Given this list of marker genes Apoe, Htt, Pld1, Ctss, Egfr, Mtm1, H2-Oa, Lamp3, H2-Aa, Ap5b1, Lamp1, Tspan15, Snf8, Rapgef2, Rab9, Mmd, Stard3, Nmnat2, Mcoln3, Slc9a6, Mapkap1, Rnf133, Lamtor1, Ankrd13d, Ifnar1, Pikfyve, Ankrd27, Yipf2, H2-Eb1, Chid1, Kcmf1, Chmp1b2, Ifitm3, Ifitm2, Cd2ap, Ubxn6, Dync1li1, Mtmr4, Atg9a, Abcb6, Sorl1, Osbpl11, H2-DMa (NCBI Gene Id 14998), Zmpste24, Trf, Gnpnat1, Kcnq1, F2r, Pmel (NCBI Gene Id 20431), Cxcr4, Grn, Lamtor4, Gja1, Mfsd12, Slc9a9, Lamtor2, B2m, Chmp2b, Apoa5, Clec16a, Clcn6, Mon1b, Slc17a8, Abca3, Spaar (small regulatory polypeptide of amino acid response), Myo5a, Rab34 (RAB34, member RAS oncogene family), Cd79a, Lgmn, Slc30a3, Cd68, Chmp1b, Vps37d, Npc1, Tmem59, Atp13a2, Tpt1, Vps16, Galntl5, Trappc9, Dnm1l, Hgs, Mvb12b, Cdip1, Unc13d, Vta1, Rab14, Cln3, Clcn3, Atp7a, Vti1b, Ddit3, Litaf, Cst7, Baiap3, Pik3r4, Rnf149, Tsg101, H2-DMb2, Ttpa, Tmem30a, Tpcn2, Chmp4b, Rab27a, Slc39a14, H2-Ea, Vti1a, Sftpc, Ctsl, Vps28, Vps39, Cst3, Cd1d1, Lipc, Atp10b, H2-DMb1, Cd74, Insr, Irgm1, Nbr1, Mreg, Prkar1b, Dennd10 (NCBI Gene Id 67894), Stx7, Atp13a5, Derl1, Chmp5, Slc30a4, Cd300lg, Vps11, Arl8b, Ankrd13b, Mapk1, Parm1, Sftpd, Rilp, Vps37a, Slc29a3, Laptm4b, Gosr2, Vipas39, Snx16, Ap5z1, Negr1, Rhob, Acp3, Crhbp, Slc31a1, Pik3c3, Stard3nl, Wdr81, Wdr48, Astn2, Rab9b, Slc38a9, Mvb12a, Stx8, Tmem9, Vamp8, Lamtor5, Lrrk2, Rubcn, Chmp4c, Steap3, Bace1, Zfyve26, Nedd4l, Vps4a (vacuolar protein sorting 4A), Src, Hspa8, Anxa2, Osbpl9, Chmp3, Atp9a, Ctns, Cd63, Rnf128, Arl8a, Vopp1, Pcsk9, Ap5s1, Arf1, Ankrd13a, Slc31a2, Tmem163, Litafd (LITAF domain containing), Fyco1, Uvrag, Anxa8, Rap1a, Slc2a4, Vps33b, Rab7b, Vps37b, Slc11a2, Smo, Lrat, Tmem106b (NCBI Gene Id 76086), H2-Ob, Mon1a, Vps4b, Micall1, Sqstm1, Slc11a1, Notch1, Vps26b, Laptm4a, Clcn4, Crhr1, Ube2a, Vps13c, Vps41, Elapor1, Arap1, Entrep1, Rab22a, Wdr91, Atp7b, Pip4p1, Dync1li2, Magi2, Vps37c, Lamtor3, Sftpb, Rmc1, M6pr, Rab27b, Atp13a4, Plekhm1, Tmem230, Vamp5, Ntrk1, Prkar1a, Map2k1, Rasgef1b, Sla2, Marchf8, Anxa6, Gapdh, Vps36 (NCBI Gene Id 76372), Vps35, Ldlr, Yipf1, Tcirg1, Lamp5, Lamp2, Rab7, Derl2, Mitd1, Ticam2, Zp2, Pip4p2, Igf2r, Siglec1, Slc1a1, Gimap5, Abhd6, Ccz1, Pld3, Kidins220, Rnf13, Abca5, Tmem25, Chmp2a, Mapk3, Tmem192, Dysf, Cyb561a3, Nsg2 (NCBI Gene Id 97776), Gfra1, Marchf1, Grin2b, Sdf4, Bltp3a, Nsg1, H2-Eb2, Slc30a2, H2-Ab1, Rnf148, Mbl2, Chmp1a, Bst2, Mbl1, Stoml1, Vps33a, Atp13a3, Osbpl1a, Slc9a8, Rab11a, Exoc8, Chmp7, Ecpas, Vps18, Ap5m1, Mr1, Mcoln1, Sppl2a (NCBI Gene Id 66552), Chmp6, Washc1, Psap, Rufy1, Map2k2, Vps8, Rab31, Map1lc3a, Sftpa1, Snx14, here is a description of the gene set: Mouse Gene Set: GOCC_LATE_ENDOSOME studied in species Mus musculus A prelysosomal endocytic organelle differentiated from early endosomes by lower lumenal pH and different protein composition. Late endosomes are more spherical than early endosomes and are mostly juxtanuclear, being concentrated near the microtubule organizing center.